Given this list of marker genes TAF15, ERBB2, RNF213, NF1, LASP1, BRCA1, CLTC, ASPSCR1, SUZ12, ETV4, MLLT6, here is a description of the gene set: Human Gene Set: MYLLYKANGAS_AMPLIFICATION_HOT_SPOT_12 from publication Myllykangas S, Himberg J, Böhling T, Nagy B, Hollmén J, Knuutila S (PMID 16751803) DNA copy number amplifications activate oncogenes and are hallmarks of nearly all advanced tumors. Amplified genes represent attractive targets for therapy, diagnostics and prognostics. To investigate DNA amplifications in different neoplasms, we performed a bibliomics survey using 838 published chromosomal comparative genomic hybridization studies and collected amplification data at chromosome band resolution from more than 4500 cases. Amplification profiles were determined for 73 distinct neoplasms. Neoplasms were clustered according to the amplification profiles, and frequently amplified chromosomal loci (amplification hot spots) were identified using computational modeling. To investigate the site specificity and mechanisms of gene amplifications, colocalization of amplification hot spots, cancer genes, fragile sites, virus integration sites and gene size cohorts were tested in a statistical framework. Amplification-based clustering demonstrated that cancers with similar etiology, cell-of-origin or topographical location have a tendency to obtain convergent amplification profiles. The identified amplification hot spots were colocalized with the known fragile sites, cancer genes and virus integration sites, but global statistical significance could not be ascertained. Large genes were significantly overrepresented on the fragile sites and the reported amplification hot spots. These findings indicate that amplifications are selected in the cancer tissue environment according to the qualitative traits and localization of cancer genes. studied in species Homo sapiens Amplification hot spot 12: colocolized fragile sites and cancer genes in the 17q11.1-q21; 17q25 region.